Given this list of marker genes Spx, Slc27a4, Irs2, Thbs1, Acsl1, Cd36 (NCBI Gene Id 12491), Akt2, Slc27a2, Rps6kb1, Slc27a6, Slc27a5, Fabp3, Acsl5, Slc2a1, Acsl6, Akt1, Abcc1, Eprs1, Acsl3, Slc27a1 (NCBI Gene Id 26457), here is a description of the gene set: The directed movement of a long-chain fatty acid from outside of a cell into a cell. This may occur via transport across the plasma membrane or via endocytosis. A long-chain fatty acid has an aliphatic tail containing 13 to 22 carbons. Mouse Gene Set: GOBP_LONG_CHAIN_FATTY_ACID_IMPORT_INTO_CELL studied in species Mus musculus